The following is a description of a gene set: The enlargement or overgrowth of all or part of a muscle organ or tissue due to an increase in the size of its muscle cells as a result of a disturbance in organismal or cellular homeostasis. species: Homo sapiens Human Gene Set: GOBP_MUSCLE_HYPERTROPHY_IN_RESPONSE_TO_STRESS, and this is the list of marker genes: ATP2B4, ATP2A2, MIR34B, ACACB, MYH7, BMP10, TCAP, MIR214, SMAD4 (SMAD family member 4), NPPA, CAMTA2 (NCBI Gene Id 23125), MLIP, MIR208A, HDAC4 (NCBI Gene Id 9759), MIR20A, INPP5F, PPARG, ERRFI1, FOXO1, MIR34C, MYH6, MIR17 (NCBI Gene Id 406952), HEY2, KDM4A, KLF15, MIR199A1, EZH2, GATA6, LMNA, SMAD3, APLNR, MIR25, TRPC3, PPP3CA